Given this list of marker genes MAP3K1, MAPK8, CDC42, PIP5K1A, CD44, VAV3, MMP9, PTK2B, CHUK, MAPK1, ITGAV, NFKB1 (NCBI Gene Id 4790), PIK3CA, GSN, NFKBIA, MMP2, RELA, SPP1, ROCK2, FOS, BCAR1, RAC1, ILK, RHOA, PLAU, MAP3K14, MAPK3, ITGB3, SYK, JUN, PIK3R1, here is a description of the gene set: Human Gene Set: PID_AVB3_OPN_PATHWAY Osteopontin-mediated events from publication Schaefer CF, Anthony K, Krupa S, Buchoff J, Day M, Hannay T, Buetow KH (PMID 18832364) studied in species Homo sapiens